The following is a description of a gene set: Human Gene Set: HP_EASY_FATIGABILITY studied in species Homo sapiens Increased susceptibility to fatigue. Easy fatigability, and this is the list of marker genes: BAG3 (NCBI Gene Id 9531), AGRN, VAMP1, SDHB, RRM2B, POMT1, MPL, LRP4, NARS2, PFKM, MICU1, TET2, TGFB1, TDP2, TYMP, SLC18A3, LAMB2, CHAT, CALR, DNM2, ACTA1, COLQ, MEN1, CHRNE, MGME1, NFE2L2, SDHA, LIG3 (DNA ligase 3), GMPPB, NTN1, DPAGT1, LDHA, POLG, HNRNPK, SYT2, ALG2, SELENON, CHRNB1, TPM3, TWNK, CCN6, PNPLA2, TPM2 (tropomyosin 2), DCC, DOK7, FKBP14, ALG14, CHRND, SNAP25, HSPB3 (heat shock protein family B (small) member 3), CASQ1, CHRNA1, PRKAR1A, SLC5A7, POLG2, MTMR14, GTPBP3, SLC25A42, CHST11, TMEM126B, SURF1, RYR1, AIP (aryl hydrocarbon receptor interacting protein), RAPSN, SDHD, AK9, ISCU, ATP13A3, MAP3K20, HACD1, SLC25A4, AGK, DNAL4, STIM1, NEB, SLC25A1, RAD51, PYROXD1, CDH23 (cadherin related 23), SCN4A, CWF19L1, MYL2, JAK2, MYPN, ITGA7 (integrin subunit alpha 7), MYO9A, GFPT1, SDHAF1, COL13A1, MUSK